Given this list of marker genes ESYT2, ESYT3, PLEKHA8, GLTP, ARF1, CPTP, ESYT1, CLN3, here is a description of the gene set: species: Homo sapiens part of: Transport of small molecules Reactome Pathway: Glycosphingolipid transport After biosynthesis on the Golgi membrane, gangliosides localize to other membranes via vesicle transport, endocytosis, and exocytosis. To decouple transport from vesicular transport of proteins, gangliosides are additionally transported via non-vesicular processes.